Given this list of marker genes Ubr3, Gje1 (NCBI Gene Id 76743), Kif18a, Cyp2c50, Ndufaf7, Dlgap1, Senp8, Nudt11, Prl7a2, Usp33, Hmcn1, Trim2, Zfp521, Smco3, Hnrnph3, Hif1a, Rab12, Smarce1, Abi1, Ifnlr1, Trim12c, Fsd1l, Reg3b, Ndc1, Matr3, Chl1, Bmi1, Zfp871, Morf4l2 (mortality factor 4 like 2), Psd3, Kif21a, Map4k3, Eif3a, Trem4, Nono, Klf10, Hipk3, Zfp367, Nek7, Zfp106, Gbf1, Mapre3, Mstn (myostatin), Mecp2, Enc1, Plekhg3, Pde6b, Vkorc1l1, Lin28b, Slc36a4, Mesd, Hccs, Tnfaip1, Sbspon, here is a description of the gene set: Genes predicted to be targets of miRBase v22 microRNA mmu_miR_5618_3p in miRDB v6.0 with MirTarget v4 prediction scores > 80 (high confidence targets). Mouse Gene Set: MIR_5618_3P studied in species Mus musculus from publication Chen Y, Wang X (PMID 31504780)